Given this list of marker genes STAT5B, LEF1, GPR18, STAT5A, TCF7, KLRC1, PTPRC, SYK, JAG2, LCK, SOX13, SOX4, EGR3, NCKAP1L, CCR9, here is a description of the gene set: Human Gene Set: GOBP_GAMMA_DELTA_T_CELL_DIFFERENTIATION studied in species Homo sapiens The process in which a relatively unspecialized hemopoietic cell acquires specialized features of a gamma-delta T cell. A gamma-delta T cell is a T cell that expresses a gamma-delta T cell receptor complex.